Given this list of marker genes Cav1, Nr1h2 (NCBI Gene Id 381996), Tsc2, Stx1b, Nr1h3, Prom2, here is a description of the gene set: studied in species Mus musculus Mouse Gene Set: GOBP_NEGATIVE_REGULATION_OF_PINOCYTOSIS Any process that stops, prevents, or reduces the frequency, rate or extent of pinocytosis. Pinocytosis is the process in which cells take in liquid material from their external environment; literally 'cell drinking'. Liquid is enclosed in vesicles, formed by invagination of the plasma membrane. These vesicles then move into the cell and pass their contents to endosomes.